The following is a description of a gene set: studied in species Mus musculus from publication Tabula Muris Consortium (PMID 32669714) Mouse Gene Set: TABULA_MURIS_SENIS_MARROW_EARLY_PRO_B_CELL_AGEING, and this is the list of marker genes: Bsg, Tmsb10, Dnaja1, Etfb, Snn